The following is a description of a gene set: Genes down-regulated in day 7 germinal center B cells versus day 40 memory B cells. To obtain insight into the genetic basis of the increase of functional activity of memory B cells over time, we compared the gene expression profiles of day 7 and day 40 NP-specific/IgG1 memory B cells, GC B cells and plasma cells in immunized WT mice and naïve B cells, before and after activation in vitro. studied in species Homo sapiens Human Gene Set: GSE11961_GERMINAL_CENTER_BCELL_DAY7_VS_MEMORY_BCELL_DAY40_DN from publication Kaji T, Ishige A, Hikida M, Taka J, Hijikata A, Kubo M, Nagashima T, Takahashi Y, Kurosaki T, Okada M, Ohara O, Rajewsky K, Takemori T (PMID 23027924), and this is the list of marker genes: BARX1, KRT222, UBL3, C9orf72, GAMT, CDCP1, ITGAX, CILK1, DSTYK, GUCY2D, CIMIP2A, TEX14, GALM, BCL2L14, GRB2, TMEM176B, STXBP3, SNX2, SLC49A4, OLFM1, MYCBP2, NPR1, DPT, NMT1, PARP9, TMCC2, SNED1, CGGBP1, SYNPO2, THSD7B, TFEC, RAB39A, CRAT, GNAT2, TSTD1, ARPC5L, MYLK, GFRA1, LRCH1, CHSY3, DLG2, TLR7, OSTF1, TMEM151A, CD68, WDR91, CSF1R, PAPPA2, ATP6V0C, LYST, ART5, PIP5K1C, FRMD5, ZC2HC1A, FRMD4A, CDKL3, ABCA5, SLC34A3, C5orf47, ARHGAP32, TMCC3, SH3BGRL, YPEL2, ASAH2, SPIB, GARIN1B, KCNK6, GNB4, CYP27A1, GDAP1L1, ADCK1, CXCR5, TEP1, MET, EPOR, DCLRE1C, RECQL5, CAPS2, BLK, PAK6, KDF1, ACVR2A, CMPK2, COL27A1, NFE2L3, C11orf54, GSDMC, GRM2, CD8B, TMEM132C (NCBI Gene Id 92293), ZFR2, RAB11B (NCBI Gene Id 9230), HOXA1, PRELID2, LAD1, SLC26A11, FBXL16, KRBA1, CIB3, SPATA18, TCF7L2, RNF180, ZNF800, CPNE2, LRRC15, CADM2, SSTR2, NIPA1, RALGPS2, TBRG1, GLIS2, CFLAR, NID1, PSTPIP2, SLC46A3, TPP1, POTEH, TMEM204, SLC2A4, KCND1, IL6, CD72, ATP2B2 (ATPase plasma membrane Ca2+ transporting 2), GPR143, TRPM2, HMGN3, LNX1, ZMYM3, CASP1, MMP9, CAMKK1, TSPAN9, DRAM1, HCN3, P2RX4, EXD1 (NCBI Gene Id 161829), SIGLEC1, FABP7, RELL1, RASA4, TNNI2, ADAP2, ZNF839, IFT57, ESAM, RGS1, GPR35, FGD2 (FYVE, RhoGEF and PH domain containing 2), FBLIM1, TRIB3, ZNF23, C3orf70, MPZL1, PTK6, RUFY3, TRIQK, SCIN, BMPER, SLC16A11, SDK1, CFB, CXCL2, LPXN, ADAMTS15, IRF6, FGD5, IDO1, SLAMF9, RASIP1, NXNL2, APOOL, CALHM6, PLEKHM3, BIRC2, FAM217B, PPP1R14A, CD2AP, FMO5, SPI1, RIGI, CTTNBP2NL, ATXN7L3B, PLD4, CSTA, SLC7A7, CD1D, RALB, NDRG4, SMIM14, CST3, NRP1, PRSS22, ZNF227, AKR1A1, RAB26, GPRC5C, A1CF, CLDN15, INPP5K, KRTAP7-1